Given this list of marker genes Cyp2j6, Cyb5r1, Ndor1, Mtrr, Cox15, Ambp, Cyb5r4, Por, Cyb5rl, Cyb5r2, Cyb5r3, here is a description of the gene set: Catalysis of an oxidation-reduction (redox) reaction in which NADH or NADPH acts as a hydrogen or electron donor and reduces a heme protein. Mouse Gene Set: GOMF_OXIDOREDUCTASE_ACTIVITY_ACTING_ON_NAD_P_H_HEME_PROTEIN_AS_ACCEPTOR studied in species Mus musculus